The following is a description of a gene set: studied in species Homo sapiens mouse primary BMDCs were stimulated with tlr ligands and gene expression changes were profiled on Affymetrix arrays Human Gene Set: GSE17721_CPG_VS_GARDIQUIMOD_4H_BMDC_DN from publication Amit I, Garber M, Chevrier N, Leite AP, Donner Y, Eisenhaure T, Guttman M, Grenier JK, Li W, Zuk O, Schubert LA, Birditt B, Shay T, Goren A, Zhang X, Smith Z, Deering R, McDonald RC, Cabili M, Bernstein BE, Rinn JL, Meissner A, Root DE, Hacohen N, Regev A (PMID 19729616) Genes down-regulated in comparison of dendritic cells (DC) stimulated with CpG DNA (TLR9 agonist) at 4 h versus DC cells stimulated with Gardiquimod (TLR7 agonist) at 4 h., and this is the list of marker genes: MRAS, HPS4, DNAJC12, ARHGEF7, PIGA, DPPA5, CXCL3, INTS11, SPINT1, CEP41, ZFAND2A, PLEKHG2, CHMP1A, RCAN3, MNT, SMARCC1, FAM216A, VPS37A, PKNOX1, IRF3, TGFBI, FNBP1, SOCS2, SVIL, THUMPD1, PDK2, NTPCR, PLPP1, ACP2, ACVR1B, IGDCC3, CERS2, GALNT4, METAP1, MAP2K3, DNAJC5, ECHDC1, SEC16A, RRAD, ZDHHC3, MAFF, EPN1, SF3A2, P2RY6, H2AX, LTC4S, SPATA13, TRIB1, HGS, CEBPZ, UBP1, RNMT, RSRC1, SAMD4B, CMC2, INPP5D, HYCC1, CEBPA, PRXL2C, ITCH (itchy E3 ubiquitin protein ligase), HACL1, ZDHHC9, SLC7A2, PIK3C2A, B4GALT6, MPHOSPH6, TJAP1, CMTM3, CTBP2, DNMT3L, SLC66A3, WDR6, USP20, SUPV3L1, SEC24D (NCBI Gene Id 9871), FERMT3, ARHGAP18, NCF2, TEPSIN, PCMTD2, YWHAG, REEP1, MGAT2, GRIPAP1, RANBP10, TXNDC17, PRNP, DNAJC8, POLR3D, SMAD4, LMOD2, TXNDC11, WAS, TMEM129, ERMP1, IL17RA, ADORA2B, SNX16, ARHGAP1, AOC1, FBRS, ZNF287, APOH, AMFR, INTS3 (integrator complex subunit 3), CDC34, ERAL1, TSC22D4, FGF13, PGAP6, TFB2M, ZNF330, TSC2, SAMD10, FNTA, SLC2A1, CCT4, NISCH, SKP1, GAS2, PHF23, WBP2, LRRK1, ABL1 (NCBI Gene Id 25), ENDOG, ERBB3 (erb-b2 receptor tyrosine kinase 3), PIM3, CSF3, NUDT3, CNOT6, ZC3H12C, PAQR7, ULK2 (unc-51 like autophagy activating kinase 2), MCFD2, UTRN, CAV1, RNF6, CREBZF, RHOG, OPN3, KLF15, RHOQ, MAP3K14, HYCC2, SELENOS, ATP1B1, SRXN1, KICS2, DONSON, ERO1A, MEF2D, PDLIM7, MYLIP, ALYREF, GNPDA1, TNIP2, METTL22, SEPTIN4, OXSM, ITGB1, STAT4, FOXN2, SEMA4B, UAP1, ZNF600, AP3S2, ADD3, COX4I2, ZNF644, SGMS1, BCL6B, RPS6, CNN2, ZMYND8, MIDN, PFKFB3, NFE2L2, TSC22D3, CRAMP1, PAPSS2, CD300A, TXNDC5, ASB8, CHRNE, TLR2, PLEKHA5, MAP4K3, CALR, AK1, PIP4P2, DPP4, LPGAT1, ALDH1A2, MEPCE (methylphosphate capping enzyme), SHKBP1, RREB1, N4BP2L1, ATP6V1B2, TES, CENPQ